Given this list of marker genes Inpp5f, Rtca, D130043K22Rik, Pten, Tnr, Kremen1, Lrig2, Neo1, Rgma (NCBI Gene Id 244058), Cers2, Epha4, Rtn4rl1, Xylt1, Rtn4r, Ptprs, here is a description of the gene set: Any process that stops, prevents, or reduces the frequency, rate or extent of axon regeneration. Mouse Gene Set: GOBP_NEGATIVE_REGULATION_OF_AXON_REGENERATION studied in species Mus musculus